The following is a description of a gene set: studied in species Mus musculus Mouse Gene Set: GOBP_REGULATION_OF_CELLULAR_RESPONSE_TO_TRANSFORMING_GROWTH_FACTOR_BETA_STIMULUS Any process that modulates the frequency, rate or extent of cellular response to transforming growth factor beta stimulus., and this is the list of marker genes: Arid4b, Sap30l, Ing2, Trim33, Snx1, Ldlrad4, Pdpk1 (NCBI Gene Id 18607), Adamtsl2, Itga8, Rnf111 (NCBI Gene Id 93836), Il17f, Htra1, Il4, Flcn, Myocd, Gdf2, Sdcbp, Cav2, Eng, Gipc1, Spred2, Cdkn1c, Wnt1, Smad3, Itga3, Pals1, Nrep, Arid4a, Ltbp1, Folr1, Nrros, Fbn1, Hipk2, Tgfb1i1 (NCBI Gene Id 21804), Lats1, Hsp90ab1, Snx6, Lrrc32, Pin1, Gdf15, Ppara, Smurf1, Rasl11b, Peg10, Bambi, Twsg1, Zbtb7a, Snx25, Wfikkn2, Cdkn2b, Il17rd, Rbbp4, Ogt, Prdm16, Brms1, Dlx1, Sap30, Slc2a10, Htra3, Glg1, Hspa5, Adam17 (a disintegrin and metallopeptidase domain 17), Adissp, Skor2, Pin1rt1, Ppm1a, Tsc22d1, Ints9, Smurf2, Snw1, Lrp1, Fbn2, Ryr1, Tgfbr3, Emilin1, Smad2, Npnt, Brms1l, Skil, Bcl9l, Spry2, Spred3, Trp53, Ing1, Zeb1, Spry1, Sin3a, Hdac2, Axin1, Thbs1, Ep300, Cited2, Chst11, Zfp703, Stk11, Lats2 (large tumor suppressor 2), Usp15, Dand5, Tgfb3, Got1, Wfikkn1, Ski, Zfyve9, Furin, Smad4, Lemd3, Vasn, Nepn, Tet1, Suds3 (suppressor of defective silencing 3 homolog (S. cerevisiae)), Lrg1 (leucine-rich alpha-2-glycoprotein 1), Dnm2, Crebbp, Fkbp1a, Sap130, Spred1, Strap, Sinhcaf, Cav3, Onecut2, Cripto, Onecut1, Fam89b, Pparg, Zeb2, Cidea, Smad7, Veph1, Rbbp7, Sirt1, Men1, Cilp, Tgfbr3l, Eid2, Hdac1, Pbld1, Aspn, Stub1 (STIP1 homology and U-Box containing protein 1), Lox, Pbld2, Cflar, Pmepa1, Fermt1, Bmp2, Sox11, Ovol2, Xbp1, Smad6, Zfp451, Cdh3, Nkx2-1, Cd109